The following is a description of a gene set: Mouse Gene Set: GOMF_PRE_MRNA_3_SPLICE_SITE_BINDING Binding to a pre-mRNA 3' splice site sequence. studied in species Mus musculus, and this is the list of marker genes: Slu7, Hnrnpk, U2af2, U2af1, U2af1l4, Zrsr2